The following is a description of a gene set: Cell surface interactions at the vascular wall species: Mus musculus Mouse Gene Set: REACTOME_CELL_SURFACE_INTERACTIONS_AT_THE_VASCULAR_WALL, and this is the list of marker genes: Ppil2, Ighv5-9-1, Itgb2, Bsg, Ighv8-13, Kras, Jam3, Jchain, Slc7a5, Ighv6-7, Sdc1, Jam2, Olr1, Ighv8-5, Igkv8-21, Dok2, Ighv8-6, Itgb1, Igkv17-121, Pf4, Slc7a11, Ighv8-9, Atp1b3, Jaml (NCBI Gene Id 270152), Cav1, Cd48, Atp1b2, Iglc2, Ighv5-17, Ighv3-6 (immunoglobulin heavy variable 3-6), Vpreb3 (V-set pre-B cell surrogate light chain 3), Proc, Ighv6-3, Ighv13-2, Igkv1-88, Itgax, Atp1b1, Tek, Fyn, Ppia, Igkv1-133, Src, Itga3, Ighv5-9, Ptpn11, Cd74, Spn, Ighv5-4, Slc7a7, Apob, Ighv7-4, Tnfrsf10b, Igkv2-109, Sdc3, Col1a1, Pecam1, Procr, Ighv6-4, Igkv11-125, Mag, Gpc1, Slc7a6, Epcam, Psg29, Slc7a9, Slc7a8, Slc3a2, Itga5, Igkv1-35, Col1a2, Shc1, Esam, Mertk, Ighv16-1, Slc16a1, Sdc4, Grb14, Igkv18-36, Selplg, Angpt1, Igll1, Glg1, Igkv1-131, Gas6 (growth arrest specific 6), Sirpb1a, Ighv8-11, Igkv1-110, Ighv3-3, Pros1, Lyn, Fcamr, Gp6, Pik3cb, Sdc2, Sos1, Itgb3 (NCBI Gene Id 268495), Angpt2, Plcg1, Fcer1g, Ighv5-12-4, Pik3ca, Ighv5-12, Ighv7-3, Fn1, Inpp5d, Slc7a10, Cd177, Ighv5-15, Itga6, Cxadr, Sirpb1b, Itga4, Itgam, Itgav, Slc16a3, Ighv7-2, Ighv3-8, Ighv5-2, Lck, Cd47, F11r, Thbd, Pik3r2, Gm5150, Ighv8-12, Ceacam1, Ighv3-4, Grb7, Grb2, Ighv6-6, Selp, Cd44, Ighv3-1, Trem1, Mif, Sirpd, Ceacam2, Igkv2-137, Vpreb1b, Ighv12-3, Psg18, Sirpa, Igkv1-135, Ighv8-8, Yes1, Pik3r1, Igkv1-117, Ighv5-16, Ighv6-5, Sell, Ptpn6, Angpt4 (angiopoietin 4), Ighv5-6, Itgal, Igkv16-104 (NCBI Gene Id 381778), Ighv8-2, Cd244a, Sirpb1c, Iglc1, Igkv1-122, Slc16a8, Igkv20-101-2, Sele, Psg22, F2, Cd84, Igkv15-103, Igha, Igkv2-112, Ighv3-5, Ighv8-4, Igkv1-99, Hras, Mmp1a, Igkv1-132, Tgfb1